The following is a description of a gene set: studied in species Mus musculus A two-stranded helical polymer of the protein actin. Mouse Gene Set: GOCC_FILAMENTOUS_ACTIN, and this is the list of marker genes: Pdlim2, Tmsb15b2, Nckap1, Pdlim7, Kptn (NCBI Gene Id 77457), Arpc3, Myo1f, Specc1l, Pdlim4, Apc2, Myo18b, Dpysl3, Arpc2 (NCBI Gene Id 76709), Specc1, Actg1, Jam3, Dusp22, Pdlim1, Map3k1, Cd2ap (NCBI Gene Id 98065), Ldb3, Diaph3, Myo6, Rac3, Tmod3, Tmsb15l, Bloc1s6, Pdlim5, Myo3a, Carmil1 (NCBI Gene Id 68732), Espn, Myo1a, Pdlim3, Myo1c, Prickle4